The following is a description of a gene set: studied in species Homo sapiens Genes containing one or more binding sites for (ZNF223) in their promoter regions (TSS -1000,+100 bp) as identified by GTRD version 20.06 ChIP-seq harmonization. Human Gene Set: ZNF223_TARGET_GENES from publication Yevshin I, Sharipov R, Kolmykov S, Kondrakhin Y, Kolpakov F (PMID 30445619), and this is the list of marker genes: CAMK2D, RICTOR, MPRIP, SUV39H2, SLC17A5, NUCKS1, GDF15, ZNF362, BOLA1, UBE3C, CD99, CCDC181, CABP1-DT, INPP5J (NCBI Gene Id 27124), CUEDC1, TMEM14C, LRRC71, SLC22A4, ARHGEF37, PABPC1, TTLL10, BCL9L (NCBI Gene Id 283149), HINT3, ASB7, PTPN12, CLSTN1, MOB3A, MAPKBP1, LZTR1, IQCN, PGM5, UFM1, GPR137, STK10, FYTTD1, ADRB1, ENSG00000224865, SEC22C, ADPGK, TSN, CDKN1C, CMC4, DHRS4L1, GBX1, MFSD12, GNE, BORCS8, STAT6, NMRAL1, PDF, SEC31A, SUV39H2-DT, ERI1, MSMP, SLC37A1, CAMK1, DTX3, ZNF529, TMEM185A, PPP6R2, ITGA1, RPS14, DHRS4-AS1, AEBP2, SF3B1, LINS1, ETV2, UBE2D3, ZNF792, MIRLET7IHG, UBQLN1, ZNF7, MIR27A, EFNA1, EIF3K, TIMM23B, TBC1D32, SLC25A45, ADAMTS1, AKR1D1, WNT2B, FUT11, FANCC, FAM221B (NCBI Gene Id 392307), NUDT5, SPRY4 (NCBI Gene Id 81848), DALRD3, YARS1, LRRC8E, RACGAP1, SHOX2, ATL1, CROCCP3, IL17RB, LINC02765, ZNF155, POLD4, ZNF546, B3GNT3, BCL2, SHKBP1, SATB2, RUBCN, RND1, LIG4, TTLL12, ATP5ME, KAT6B, RCAN1, TBC1D25, KDM6B, MSRA-DT, TTC1, TMEM8B, RSRC1, FES, UBTF, MLLT6, CHDH, TPD52L1, AGMAT, NR2F1-AS1, ABCB6, SNORD35B, UBA1, SNHG30, ECI1, DDX59, PGLS-DT, TUBG1, COG2, MARK3, FAM20A, SEPHS1, IGF2BP1, RRN3P1, FHIP1A-DT, TMEM9, PLEKHH3, SLC35F2, PTS, SEC24D, EOGT, ALG11, SPPL2A, BTG1-DT, MYL5, RETREG3, ST6GAL1, ZMPSTE24, BTG1, P4HA2, CREB3L2, CMTR1, CWC25, CDC42SE1, CPTP, LHX1, CATSPERG, KCNH6, OR1X5P, ZNRF2, ISYNA1, RNU6-947P, CDK14, HIVEP1 (HIVEP zinc finger 1), PEX14, NCDN, SMARCAD1 (SWI/SNF-related, matrix-associated actin-dependent regulator of chromatin, subfamily a, containing DEAD/H box 1), TMEM14B, MYOM3, TCEANC2, IL13RA1, EMC3, ZMPSTE24-DT, BRWD1, ST3GAL6, PLD3, RASGEF1C, ABCC4, SMARCAD1-DT (NCBI Gene Id 101929210), KICS2, FAM185BP, FAM185A, SYMPK, MIR4500HG, CASK, CADM2, KCNN2, GATA2-AS1, CASTOR3P, RAB10, PHRF1, VANGL1, ENSG00000207751, LAMP1, DDX46, MIR3189, USP14, ABCB10, COMMD5, EOGT-DT, PTPRG, IZUMO4, TTLL13, FGF9, VTN, BORCS8-MEF2B, ZNF529-AS1, NUMBL, PPP2R2C, LYNX1, KLKP1, PLA2G15, BRCC3, DGAT2, NSG1, IL12B, TGFB1I1, EGLN2, AKR1A1, MIR23AHG, INTS11, RFC2, MIDN, PPP2R5B, LHX1-DT, DBF4B (NCBI Gene Id 80174), VWA5B2, MED21, MIR301B, TMTC2, CEP170, ZNF165, TLK2, POPDC3, PRIMA1, FBF1, RNF187, TNFRSF19, TMEM179B, OCLN, ACLY, TAB2, RFXANK, BRD4, PISD, EMC3-AS1, HNRNPLL, CDC123, ZNF503-AS2, APCDD1, PDZD7, MCTP1, XPOT, LINC01311, PLAAT1, NAV1, NHSL3, CNBP, FNTA, KPNA1, SPRY2 (sprouty RTK signaling antagonist 2), CERKL, PELO, KCNK2, ATP6V0A1, CYP2R1, CMTR2, TTLL6, ATL2, PWWP3A, CCDC146, KIAA0319L, KRT13, TDRP, MIR23A, ICAM3, DCUN1D2, GARNL3 (NCBI Gene Id 84253), PPP1R12C, SDCCAG8, MTCP1, ST3GAL5, PDIK1L (PDLIM1 interacting kinase 1 like), DMAP1, KLHDC10, ATP7B, S100PBP (S100P binding protein), TIMM44, TMEM132E, MZT2A, NMRK1, SFXN2, NRN1, TMEM132E-DT, SUPT3H, TBC1D4 (NCBI Gene Id 9882), BMPR1A, SPSB2, CORO2B, UBQLN1-AS1, CPN2, CDKN1B (NCBI Gene Id 1027), FCHSD2, TMCC3, MYLK (myosin light chain kinase), DEPDC5, LINC02073, LINC00431, ST3GAL6-AS1, SCAF4, ADORA2A, RASSF1-AS1, ATF6-DT, SPRY4-AS1, ACOT7, PARG, ARNT, REX1BD, ANK3, ATF6, GATA2, TMCO3 (NCBI Gene Id 55002), RTRAF, SRSF4, MTMR7, GPS1